The following is a description of a gene set: studied in species Homo sapiens Human Gene Set: GOBP_SEQUESTERING_OF_EXTRACELLULAR_LIGAND_FROM_RECEPTOR The process of binding or confining an extracellular signaling ligand, such that the ligand is unable to bind to its cell surface receptor., and this is the list of marker genes: MICOS10-NBL1, DAND5, CER1, CD46, FBN1, NRROS, GREM1, FBN2, NBL1, GREM2, LTBP1